The following is a description of a gene set: Mouse Gene Set: RUVBL2_TARGET_GENES from publication Yevshin I, Sharipov R, Kolmykov S, Kondrakhin Y, Kolpakov F (PMID 30445619) species: Mus musculus Genes containing one or more binding sites for (Ruvbl2) in their promoter regions (TSS -1000,+100 bp) as identified by GTRD version 20.06 ChIP-seq harmonization., and this is the list of marker genes: Prepl, Brpf1, Mir1894, 4632411P08Rik, Gstcd, Zzef1, Cbx3, Prcp, Glt1d1, Urb2, Sars2, Rbl1, Ube2i, Snrpe, Dapk3, Lmnb1, AA474408, Chek1, Naa38, Gmnn, Mir8092, Zfp748, Polk, Ints8, Emc4, Mirlet7i, Atraid, Klf11, Slirp, Zfp426, Aftph, Rpl10a, Hnrnpf, Tmem129, Lpcat4, Tial1, Epb41l4aos, Mapre1, Mtg2 (NCBI Gene Id 73051), Dot1l, B3galnt2, C87436, Gpn1, Chmp6, Mrpl49, Serbp1, Sgo1, Gm15719, Phactr1, Zfp882, Dnaja3, Grk4, Pex3, Rcl1, Cstf1, Pole3, Mfsd13b, Gatad2b, Rpl28, Nptn (neuroplastin), Insig1, Poli, Dnajc14, Wdr82, Pgap2, Cdipt, Rnf17, Cdc40, Lsg1, Cyp4f17, Nme1, Arglu1, 2310010J17Rik, Emc1, Cenpv, Atf2, Exog, Nphp3, Pdcd11 (NCBI Gene Id 73741), Nup88, Fbxo33, Mpdu1, Ppp2r1b, Nedd8, Gm26631, Snapc5, Cdt1, Atf5, Gpatch3, Tbrg1, Zfp62 (NCBI Gene Id 22720), Rpl9, Cc2d1b, Ss18 (SS18, subunit of BAF chromatin remodeling complex), Caprin1, Tacc3, 2610318N02Rik, Rpl11, B230369F24Rik, Herc3, Mrps24, Ccdc167, Cr1l, Mplkip, Zfp1, Taf6l, Hmgb1, Upf3a, Gm13067, Wdr20, Snora7a, Map1b, Banf1, Sec24a, Yeats2, Tomm40l, Ikzf5, Snord49a, Zfp518b, Rad9b, Pank2, 4930455B14Rik, Cul1, Mrpl27, Krr1, Maml1, Arid4a, Ctdnep1, Rpl30, Ppp1r10, B4galt7, Trmt10c, Rpl31, Cfap68, Eif4e, AI837181, Eef2 (NCBI Gene Id 13629), Npm1, Arfgef1, Mapk1, Gm27017, Nif3l1, Rbks, 4732491K20Rik, Zfp622, Nae1, Pafah1b1, Med17, Rbm15, Pum2 (pumilio RNA-binding family member 2), Pim1, Zfp639, Ubr4, E2f6, Atp9a, Gm13783, Tmem68, Dcaf8, Psmd12, Picalm, Jmjd6, 2410006H16Rik, Mcee, Cops7b, Celf1, Nfya, Prodh, Rars1, Gm13136, Rfx7, Abhd10 (abhydrolase domain containing 10), Atp5if1, 2700049A03Rik, Cdc20, Rnf14, Tex14, St7l, Zfp644, 3110031N09Rik, Dbt, Gm43403, Tars2, Aagab (alpha- and gamma-adaptin binding protein), Psma2 (NCBI Gene Id 19166), Commd6, Pcdha1, Alg11, Ccnl1, Gm25296, Mis12, Nipsnap3b, Srcap, Pphln1, Canx, Tbrg4, Kat8, Pole4, Gm22489, Med24, L3mbtl2, Sdad1, Rab6a, Senp6, Mrps12 (NCBI Gene Id 24030), Mfsd11, Arcn1, Ero1a, Mtf2, Gm13228 (NCBI Gene Id 118568704), Dync1li1, C130036L24Rik, Nop2, Pold1, Mtfr1l, Ino80b, Zc3h10, mt-Tv, Rab1a, Emsy, Gm12101, Dleu2, Gm24044, Atr, Pabpn1, Mir6236, Rad54b, Dnttip2, Msl2 (NCBI Gene Id 77853), 2900009J06Rik, Ccar1, Tatdn3, Rprd1b, Cdiptos, Zbtb2, Dgcr2, Ubxn2a, Ccdc126, Angel2, Dna2, Agpat1, Nudcd2, Stard3nl, Ccnb1, Prr11, Gdpd4, Nifk, Srd5a1, BC005537, Tbc1d2, Hsp90b1, Eif4a1, Zkscan8, Uckl1, Magoh, Pik3r3, Zfp617, Fau, mt-Tw, Zmiz2, Gm16630, Mettl23, Ube2j2, Rprd2, Psma8, Rpa2, Arid1a, Eif2a, Kmt2e, Coa7, Hsph1, Gcsh, Dyrk1b, Hmgn1, Nup50, Zfp988, Rpl19, Ypel1, Taf8, Rpl3, Zcrb1, 1110002L01Rik, Slbp, Rabggtb, Golga7, Kctd21, 5031425E22Rik (NCBI Gene Id 75977), Drap1, Lyrm7, Cdc73, Xylt2, 2610507I01Rik, Morc3, Fbxo34, Snrnp40, Khdc4, Tgs1, Leprot, Capza1, Wars1, Cdk6, Dpy30, Dennd4a, Dnajc2, Prrc2c, Vamp3, Mrtfa, Gm28050 (NCBI Gene Id 102636013), Ptpn20, Fiz1, Eif2ak1, Ears2, Mpst, Gpr176, Snord42b, Iqgap1 (NCBI Gene Id 52178), Gm13267, Rpl15, Tmco1, Smyd5 (NCBI Gene Id 232187), Gm5113, Mxd3, Snx5, Gas2 (growth arrest specific 2), Bzw2, Krt86, Smc3, Hexim2 (hexamethylene bis-acetamide inducible 2), Ubr3, Gm10766, Sec62, Med4, Tmem203, Zfp422, Rps5, Ap4m1, A930005H10Rik, Zfp236, Zwint, Tm2d1, Pgbd1, Scyl3, Eef1akmt3, Paox, Ints1, Psmg3, Pi4kb, Ppil3, Rpl22l1, Gm11527, Ing4, Znhit1, Mtmr7, Zfp664, Lmbr1, 3110056K07Rik, Mm2pr, Msantd7, BC051226, Hmgn2, Gm7008, Gm23639, 4930540M05Rik, Btbd7, Gm9929, Taf4, Med28, Ccdc181, Slc36a1, Csrp2, Gm15834, Kdm1a, Metap1, Agps, Dennd1a, Snhg5, Thg1l, Rpl27, Rpain, Gm12258, Wsb1, Etfb, Homer3, Eif1a (eukaryotic translation initiation factor 1A), Utp18, Ptp4a1, Abraxas1, Oasl1, Ubl7, Ncdn, Tamm41, Mtrfr, Polr2k, Prpf38b, Gm7285, Fbxl18, Tmem198b, Fam227b (family with sequence similarity 227, member B), Spcs1, Elob, Sp4, Gmeb2, Ddx39b, Rps26, Smg8, Zfp763 (zinc finger protein 763), Cnpy4, Sp1 (NCBI Gene Id 68485), Pds5a, Psrc1, Derl2, Ubfd1 (NCBI Gene Id 28018), Ppp4r1l-ps, Trappc8, Klhl11, Mvb12a, Pla2g1b, Stk11, Cyb5d1, Txndc17, Eif4h, Cfap52, Tmed7, Sfi1 (Sfi1 homolog, spindle assembly associated (yeast)), Heatr6, Tpx2, Mpz, Pias4, 5430416N02Rik (RIKEN cDNA 5430416N02 gene), Rft1, Eif2d, Nkiras1, Zfp518a, Wac, Dnajc25, Ing3, Gtpbp6, Hnrnpab, Tnfaip3, Usp38, Bmpr2, Tor1aip2, Phb2, Snord43, Tmem199, 2810029C07Rik, Txn2, Krcc1, Hmga1b, Ddx17, Phc3, Mesd, Nufip1, mt-Nd1, Znrf3 (NCBI Gene Id 407821), Atpaf2, Mex3a, Ifit2, Hddc2, Rnf220, Pex12, Dhcr24, 1810059C17Rik, Uqcrc1, Mks1, Ctnnb1, Chd6, Pym1, Hspbap1, Car7, Zfp414, 1700065D16Rik, Gm13884, Zbtb45, Mthfr, Tef, Srsf3, Tubd1, Apaf1, Mrnip, Dcaf15 (NCBI Gene Id 212123), Mrpl18, Med1, Thap6, Tsacc, Ddx47, Frmd6 (FERM domain containing 6), Smim27, Ttc14, Elp5, Malat1, Phip, Zcchc17, 9430065F17Rik, Dhx35, Sugp2, Dnajc13, Ttk, Zc3hav1l, Naa12, Gtf2a1, 1810024B03Rik, Mphosph10 (M-phase phosphoprotein 10 (U3 small nucleolar ribonucleoprotein)), Usp1, Uqcr10, Mrps31, Ankfy1, Crlf3, Mfsd14a, Mir8102, Eif5a, Polr1f, Rad17, Pcid2, Taf12, Stard6, Rpl32, Ssr3, Cul2, Ost4 (oligosaccharyltransferase complex subunit 4 (non-catalytic)), Plcg1 (NCBI Gene Id 99130), Gm37450, Dbr1, Sco1, Khdrbs1, Atrip, Scfd2, Arhgdia, Man2c1, Zfp764l1, Arrdc3, Lyrm2, Hnrnpdl, Btaf1, Gm26533, Prpf8, Pxmp2, Cct3, Cdc27, Tex19.1, Actr1b, Arf6, Adprs, Tm9sf2, Cstf3, 3110053B16Rik, Prkrip1, Dctn4, Mrgbp, Clpb, Txndc15, Abl2, Fbxl19, Gabpb1 (GA repeat binding protein, beta 1), Gtf2h5, Sap30bp, Zcchc4, Smim8, Hnrnpa3, Ccdc18, Kdm3a, Smndc1, Ddx5, Plod3, 4933433G15Rik, Polr2f, Yy1, Smg6, Edrf1, Afg1l, Lrch3, Dcaf17, Arrb2, Zfp369, Crk, Ndufaf8, Wdr43, Cox18, Apc, Hbp1, E2f3, Rpp25, Eme1, Esyt1, Babam2, Eif4g1, Gm8357, Rnf5, Tube1, Sh3gl1, Nr1h3, Lipe, 4930519P11Rik, Atg16l1, Copg2, Phf12, Ccdc92, Ip6k2, Tent4b, Nup98, Tcaf2, Psmc2, Zfp810, Eif5, R74862, Gtf3c6, Tfam, Dnajb6, Mrpl12, Spmip5, Rif1, Ppp2r1a, Rbbp4, 2610008E11Rik, B230217O12Rik, Mir301b, Tinf2 (NCBI Gene Id 28113), Atrnl1, AU040320, Cep72, Brk1, Ranbp6, Zfp68, Mgme1, Recql5, Cox16, Lonp2, Wasl, Cntnap2, Atxn3, Dnlz, Sfxn5, Chmp7, Ggct, Gm3807, Dcaf12, Tomm7, Gtf3c5, Wee1, Hemk1, Ddx21 (DExD box helicase 21), Azin1, Gpalpp1, Ywhae, Kat6a, Matr3, Hdgf, Lias, Rasa1, Hadha, Phlda3, Cspp1, 2610005L07Rik, Nusap1, Safb2, Zcchc8, Rpl27a, Suz12, Srp68, Dnajb12, Zfp672 (NCBI Gene Id 68181), Aktip, Fhip2a, Cdkal1, Lyar, Tlk2 (tousled-like kinase 2 (Arabidopsis)), Fbxo28, Arhgef18, Snhg8, Rpl21, Nup188, Mrm2, Cd2bp2, Vps13a, Ttc27, Twnk, Nubpl, Nbr1, Ifrd1, Acadsb, Pih1d2, Slc5a6, Cnpy3, Elp2, Zfp524, Sqle, Rnu11, Esco1, Wnk1, Mir1938, Kdm5a, Duxf4, Pfas, Uqcrq, AU041133, Ppie, Anapc13, Alkbh1, Aco2, Mtln, Zmym5, Odf2, Top3a, Slc12a6, Ndufc1, Mrpl11, Hnrnpa2b1, Psmb1, Atp6v1h (NCBI Gene Id 98576), Tanc1, Poldip2 (NCBI Gene Id 67811), Tas1r1, Syvn1, BC004004, Asns, Tars1, Ighv1-67, Tmem208, Hnrnpa0, Zfp740, Mark3, U2surp, Pde3b (NCBI Gene Id 381911), Zmynd8, Ahcyl2, Ubap2l, Mir8112, Vps52, Rpf1, Rnps1, Prkcb, Pou2f2, Cert1, 4933427D14Rik, Drg2, mt-Tq, Hmmr, Pik3r2, 4930503L19Rik, Naa15, Map1lc3a, Slu7, Ube2s, Gm22417, Nop58, Taf5l, Gnpat, Gm26224, Pigt, Rps9, Zdhhc4, Ssbp1, Ppp1r8, Ncbp3, Ndor1, Eif4g2, Rnf38, Alg9 (ALG9 alpha-1,2-mannosyltransferase), Rpl22, Gm5067, Pbk, Supv3l1, Smg5, Hspa8, Armc6, Tcerg1, Cep112, Rpl26, Appbp2, Ganc, Bag4, Srsf11, Ing1 (inhibitor of growth family, member 1), Ank1, Ccdc25, Prc1, Ogfod2, Zfp36l1-ps, Arhgap17, Ccdc157, Skic2, Abi1, Mettl8, Pfdn2, Ighv8-14, Airim, Sh3bp5l, Gm22589 (predicted gene, 22589), Rpl36, Rack1 (NCBI Gene Id 14694), Plbd2, Hectd1, Atp5f1c, Sdhc, Vps29, Ranbp1, Rimoc1, Klhdc10, Mrpl9, Brca2, Gabpb2, Gm16001, 4930507D05Rik, Ell, Sucla2, Cluh, Rev3l, C130060C02Rik, Pts (6-pyruvoyl-tetrahydropterin synthase), Gm26608, Mir707, 1700113A16Rik, Srfbp1, Snhg17, Ifnar2, Yes1, Zmym4, Natd1, Gm27003, Atpsckmt, Rps18, Ap1g1, Hectd2, Taf3, Cfap298, Use1, Ccdc90b, Cipc, Man2c1os, A730081D07Rik, Ndufc2, Mir7654, 4931406C07Rik, Dusp3, Park7, Gnaq, Zfp568 (NCBI Gene Id 97388), Nop56, Sdccag8, Fam219b, 0610040B10Rik, Srp19, Dhps, Pafah2, Trmo, Ptma, Kti12, Iqch, Rpl13a, Zfyve16, Ndufb5, Mettl4, Asl, Pdia5, Ptbp1, Ppa1, Trpm8, Gm15535, Blcap, Zdhhc2, Ncapd2, Gm15545, Son, Washc4, Msantd2, Xpo1 (exportin 1), Dynlt1b, Gm13562 (NCBI Gene Id 115489442), Tm9sf3, Gm28047, 2810004N23Rik, Gm15320 (predicted gene 15320), Rnf169, Htt, Rhebl1, Ubxn7, Zfp696, Scarna2, Nmt2, Cct5, Wars2, 2010320M18Rik, Ssmem1 (NCBI Gene Id 75647), Ddx6, Glp1r, Mrps18a, Rnaseh2b, Psme4, Mir320, Eef1g, Polr3h, Ppan, Xpc, 5330439K02Rik, Gm26800, Odf2l, Ak6, Rpp30, Pggt1b, Ezh2, Ube2c, Mtch1, Mphosph9, Zcchc10, Kmt2a, Ubxn6, Dhcr7, Yeats4, Kpnb1, Poldip3, Gm20186, Lsm3, Gm15564, Mrps18b, Pofut2, Srpra, Vps37a, Intu, Tyw5, Mrpl22, Nsun4, Yap1, Srr, Bbs10, Ptk2, Sec61a2, Prdm9, Ech1, Brd2, D330023K18Rik, Dek, Snora17, Tmem168, Polrmt, Letmd1 (NCBI Gene Id 68614), 1810019N24Rik, Gpbp1, Ccdc103, Cdr2, Gid4, Uckl1os, Kri1, Gatc (NCBI Gene Id 76526), Zbtb21, Raver1, Hnrnph1, Cdk11b, Fignl1, Kmt5a, Mapk6, Duxf1, Rnf44, Tmem79, Uso1, Tnpo1, Gm16023, Slc25a51, Rabgap1, Wdr59, Tnrc6c, Gm57857, Taf1d, Gm38293, Akap13, Mrps2, Xpot, Tyms, Dcp1b, Atf1, Ints12, Gatb, mt-Ti, Rcbtb1, Cobl, Lrif1, Dync2i2, Cse1l, Oxa1l, Atp5pf, Atg14, Mettl1, Zfp266, Glod4, Pik3c3, Toe1, Prmt5, Il4i1, Kif20a, Hjurp, Map3k4, Eci1, Taf2, Psmc5, Arhgap11a, Utp3, Nelfb, Sfpq, Crcp, Usp35, Fbxl9, Psmb7, Rsl24d1, Fam229b, 3110082I17Rik (NCBI Gene Id 73212), Sart3, Fancf, Agpat5, Tbc1d7, Cbx1, Tsnaxip1, Ranbp17, Mul1, Gramd1b, Pus3, mt-Nd5, Ints9, Slc6a16, Haus3, Odad3, Spin1, Hint2, Gm26559 (NCBI Gene Id 102639339), Hpf1, Cop1, Osbpl9, Erich1, Snhg7os, Acp6, A330023F24Rik, Ndc1, Sec24c, Laptm4a (lysosomal-associated protein transmembrane 4A), Narf (nuclear prelamin A recognition factor), Atad2, Oxsr1, Ddias, Farsa, Gpcpd1, Nfx1, Aen, Snx17, Bscl2, Esyt2, Zmat5, Dtl, Mad2l1, Atp7b, Hnrnpu, Snord68, Nol9, E230029C05Rik, Srsf6, Rpl29, Ccnc, Iscu, Mroh8, Uspl1, Cep95, Gm15860, Brpf3, Hcfc2, mt-Th, Zfp11, Nob1, 1700037C18Rik, Spock1, Clcn6, Cep78, 8430429K09Rik, 1700112J16Rik, Nkapd1, Naa25, Mettl2, Hmbox1, Gfpt1, Dnajc11, Mir1934, Gtf3c2, 2500004C02Rik, Tnpo3, Uhmk1, Cep170, Ago3, Spry1, Cyb561a3 (cytochrome b561 family, member A3), N6amt1, Endov, mt-Tl1, Arfgap2, Fbxo36, Spc25, Ddb1, Rxylt1, Lrrc59, Gm10433, Nsun2, Gm10222, Rnu12, Alkbh5, Atpaf1, Tsg101, Clptm1l, Ldha, Rnpepl1, Terf2, Slc27a3, Tmf1, Ckap2, Gm13162, Mrm3, Ngrn, Bloc1s2, Polr2a, 4632404H12Rik, Zfp37, B3galt4, Gm2762, Dido1, Tsc2 (NCBI Gene Id 22084), Taf9, Gm10699, Pstk, Gm9245, Zfp689, Lrrc28, Ttc39d, mt-Rnr2, Itsn2, Ift27, 0610009E02Rik, Psmd11, Zbtb37, Eef1akmt2, Itgb1bp1, Cirbp, Zfp706, Ik, Gm13033, Ap2b1, Map2k2, Atp6v0a1, Mrpl45, Fbxo22, Gdf9, Rps6, Eef1b2, Dlg1 (NCBI Gene Id 320792), Rhbdd3, Ppp1r12b, Ogg1, Snord3a, Taf7, P3h1, Stard7, Prkcsh, Vmn2r-ps20, Gm2093, Ilf2, Cul4a, Zbtb11, Eif4a3, Mtrex, Ppa2, Myl4, Atp6v1d, Trim39, Arf1, Bptf, Stag1, Nubp1, Smarcc1, Paqr5, Timm21, Dph5, Cebpz, Cfap69, Tert, Plekhb1, Nufip2, Stx12, Nutf2 (nuclear transport factor 2), Itm2b, Mtr, Vamp2, Reps1, Gm13483, Rrp1b, Ppp4r3b, Tet2, Pou2f1, Tti1, Tmem138, Phf5a, Ensa, 2210406O10Rik, Mdc1, Ttc9c, Chuk, Kbtbd12, Pwp1, Patz1, Sugct, Ctbp1, Mllt10, Gm17690, Spag7, Stt3b, Chac2, Mrpl43, Zfp292, Szrd1, 4930577N17Rik, Myh10, Itgav, Rnf185, Cox20, Gm26868, Csnk1d, Rexo4, Med13 (NCBI Gene Id 68851), Nup85, Kif20b, Tkt, Cdc37, Cbl, Copz1 (NCBI Gene Id 80513), Dtwd1, Kmt2d, Trmt2a, Ulk4, Clptm1, Rbm45, C1qbp, Rps15a, Sgf29, Ehmt1, Suv39h2, Mrpl42, Spag5, Cpsf1, Ints7, Zfp148, Zfp383, Rpl7l1, Dhx29, Znfx1, Tepsin, Ndufaf7, Usp45, Gm32950 (NCBI Gene Id 102635671), Tst, Mphosph8, Pask, B230354K17Rik, Rpl14, mt-Ts2, Atf7ip, Glg1, mt-Nd2 (NCBI Gene Id 99241), Gnb2, Phkb, Tgfbr1, Etaa1os, Vezf1, Armh3, AU022252, Supt7l, Fam168a, Nit1, Platr4, Grk2, Ikbip, Prrc2a (proline-rich coiled-coil 2A), Crkl, Zfp866, Mrpl51, 4933434E20Rik, Mrpl39, Pgs1, Cep85, Erlin2, Pura, Slc2a3, Cnot4, H2az1, Slc4a1ap, Chaserr, Zfp143, Daxx, A330035P11Rik, Cisd2, Polr3d, Trmt44, Adprm, Gm10941, Ndufv1, Pum1, Tarbp2, Mtch2, Srsf1, Gm10373, Skap2, Fbxl3, Mcm7, Slc35e2, Dpagt1, 6030443J06Rik, Brca1, Idh3b, Gpr19, A430105J06Rik, mt-Tl2 (mitochondrially encoded tRNA leucine 2), Sec16a, Vmac, Usp30, Gnl3l, Otud4, Gars1, Hs2st1, Bola3, Slc30a5 (solute carrier family 30 (zinc transporter), member 5), Usp32, Mdp1, Eftud2, Eny2, Pan2, Trit1, Pccb, Eif1ad (NCBI Gene Id 69860), Gm15541, 1700030C10Rik, Rad23a, Haspin, Mnat1 (menage a trois 1), Mtss1, Cdv3, Cwc22, Tut4, Rps6ka5, Gm13034, Krba1 (KRAB-A domain containing 1), Timm50, Rpl23a, Rfc4, Primpol, Col26a1, Triap1, Kansl2, Ap1m1, Polr2d, Mfsd5, Rrp15, Ube2q1, Tsen15, Exo1, Mutyh, Dolk, Isy1, Galk2, Abca4, Kin, Tardbp, Cep250, Kctd15, Asxl1, Serac1, Orc5, Ubn2, Mrto4, Parp11, Srsf2, Eapp, Wdr25, Gpr137, Ddx23, Mrpl54, Lysmd4, Atf6, Kcnn2, Mtf1, Amz2 (archaelysin family metallopeptidase 2), Lyrm4, Lockd, 4930412F09Rik, Atg13, Mir130b, Poglut1, Mospd3, Topors, Smurf2, Hrob, Sde2, Plekhm3, Sf3b4, 2700099C18Rik, Stx8, Zfp867, Nr2c2, Paip2b, Aspa, Nt5m, Yif1a, Snord49b, Ndufb8, Cryz, Nup58, Kptn, Zfp526, Gm12522, Zfp936, Riok3, Snord15a, Snora24, Tab1, Rpl36al, Rpn2, Hells, Zscan25, Zfp998, Mrpl58, Tbca, Dbil5, Safb, Mgat4a, Slc39a6, Sumo2, Tbc1d17, Ankmy2, Eef1a1, Nsl1, Ccdc61, Tmem214, Mfn2, Dyrk1a, Rmc1, H2-T9 (NCBI Gene Id 630294), Gigyf2, Ermp1, Atp5mf, Snord110, Pdss1, Zbtb8os, Rps6kb2, Sar1b, Prmt3, Eif5b (eukaryotic translation initiation factor 5B), Hadhb (hydroxyacyl-CoA dehydrogenase trifunctional multienzyme complex subunit beta), Yju2, Mir5615-1, mt-Tm, Atp6v1a (ATPase, H+ transporting, lysosomal V1 subunit A), Mgat2, Cltc, Tbc1d22a, Gm6288, Frmd5, C2cd5 (NCBI Gene Id 77314), Ndufa10, Ndufs4, Pole, Ift46, Cox10, Gm25878, Usp36, Poln, Idi1, Nemf, Mrps11, Ciapin1, Casp3, Mir7655, Thap3, Gga3, Trip12, Pip4k2b, Kansl1, Trim33, Mbtd1, Scfd1, Gm23034, Gm5540, Atf7, Cd1d1, Wasf2, Cyb5r1, Snhg16, Gas5, 4933406I18Rik, Spg7, Slc43a1, Abcd3, Syn3, Acp2, Kcnt1, Scamp2, 4930483J18Rik, Rbm7, Pak1ip1, Gm11457, Rbm4b, Rrm2, Anapc5, Harbi1, Rsrp1, Birc5, Gm26590, Rpl8, Gid8, Rps3, 1700007L15Rik, Usp21, Foxred1 (FAD-dependent oxidoreductase domain containing 1), Supt16 (SPT16, facilitates chromatin remodeling subunit), Gart, Mgst3, Ints13, Cep63, Atp5mk, Gk5, Trap1, Wdr74, 4930509E16Rik, Spcs2, Psmb6, 1700084C06Rik, 4933424G06Rik, Slain2, Gbp3 (guanylate binding protein 3), Hmgb2, Aar2, Adam17, Rpl13, Gm22357 (NCBI Gene Id 115487638), Rpap1, Lsm14a, Snora3, Ndufs2, Cluap1, Asf1b, Micos10, Swsap1, Snord45c, Slfn10-ps, Bad, Snrnp200, Rab22a, Fbxl12os, H2ax, Tpgs1, Bbs5, Alad, Gpr107, Ankrd50, Gmpr2 (guanosine monophosphate reductase 2), Rras2 (NCBI Gene Id 97407), 2810001G20Rik, 2610037D02Rik, Mau2, Tfb1m (NCBI Gene Id 224481), Hdhd5, Rabif, Prpf18, Camkmt, Rbm12, Gm29609, Cers5, Rchy1, Akap1, Etf1, Nudt1, Rbm5 (NCBI Gene Id 83486), 1700088E04Rik, Rab29, Snrpb, Dhx36, D330041H03Rik, Rpf2, Rbm8a, Hdac4, Eif2ak3, Mrpl55, Xpo6, Mpnd, Timm9, Zfp668, Smcr8, Rps6kb1, Cdnf, Cyb5d2, Abcg2, Ap2m1, Cux1, Slc25a26, Zbtb17, Mael, Cript, Rpl41, Unc13b, Chd2, Zfp329, Cpne1, 6820431F20Rik, Lsm8, Lonp1, Nfu1, Ube2g1, Lars2, Eed, Thoc3, Xrcc5, Cdc23, Raf1, Ppm1d, Lamtor1, Cln3, Gm16794, Cops6, Srm, E130307A14Rik, Runx1t1 (NCBI Gene Id 12395), Tnfrsf22, Naa20, Ppp1r14a, Trappc2b, Cdkl2, Ndufs1, Ndufa12-ps, Emg1, 6330549D23Rik (NCBI Gene Id 329717), Mrps7, Akt1s1, Eif2b4, Cops7a, Pabpc1, Mnt, Tstd3, Necab3, Ccnf, Dnmt1, Rpsa, Zfp120, Sugp1, Atp5f1a, Tada2a, Srpk2, Tmem45a, Ankrd40, Maip1, Tob1, Ftsj3, Rhot1, Lsm1, Zfas1, Dohh, Ccng2, Sf3a2, Hic2, Ccdc77, Pemt (NCBI Gene Id 18618), Gm12743, Rpl34, Txndc9 (NCBI Gene Id 98258), Jam3, Fbxw17, Setd3, Tsr1, Thumpd2, 2310057M21Rik, Dock8, Aip, Psmd3, Zfp202, Zdhhc17, Coq9, Ndufa11, Flywch1, Gm11399, Cnot7, Slc2a1, Lrch1, Gemin4, 4933430I17Rik, Rrn3, Zap70, Sumo1, Dhx30, Pnrc2, Taf6, Tvp23a, Utp11, Nr3c1, Xrn1, Rpl5, Fbxw11, Acaca, Cbx2, Rpusd2, Tcp1, Mmadhc, Epo, Cct6a, Wdr5b, Trmt61a, 1700023H06Rik, Snord1c, Mrpl32, Spata31e2, Rptor (NCBI Gene Id 74370), H3c6, Zfp646, Sltm, Gucy1a2, Dph1, Cetn3, Ppp1r7, Stat3, Gm10524, Ston2, Sec31a, Rad52, Dnph1, Gm15247, Msh2, Arfgef2, Aarsd1, Zfp990, Zfp989, Mir7075, Chrac1, Hspa9, Zbtb49, Snrnp70, Psmd5, Rsbn1, Cdca8, Tmed4, Haus4, Psph, Taf5, Fastk, Rbmxl1, Xkr6, Cand1, Aurka, Wdr4, Gmds, Aars2, Xrra1, Mapk8ip3, Cep164, Tra2a, Fam13b, Ran, Agfg1